The following is a description of a gene set: An adenylate cyclase-activating G protein-coupled receptor signaling pathway initiated by dopamine binding to its receptor, and ending with the regulation of a downstream cellular process. species: Homo sapiens Human Gene Set: GOBP_ADENYLATE_CYCLASE_ACTIVATING_DOPAMINE_RECEPTOR_SIGNALING_PATHWAY, and this is the list of marker genes: ADCY5, NHERF1, GNB1, GNAL, DRD3, ADCY6, GNG2, PTGER1, GNAS (GNAS complex locus), DRD5, DRD1